The following is a description of a gene set: species: Homo sapiens Reactome Pathway: HIV Life Cycle part of: HIV Infection The life cycle of HIV-1 is divided into early and late phases, shown schematically in the figure. In the <b>early</b> phase, an HIV-1 virion binds to receptors and co-receptors on the human host cell surface (a), viral and host cell membranes fuse and the viral particle is uncoated (b), the viral genome is reverse transcribed and the viral preintegration complex (PIC) forms (c), the PIC is transported through the nuclear pore into the nucleoplasm (d), and the viral reverse transcript is integrated into a host cell chromosome (e). In the <b>late</b> phase, viral RNAs are transcribed from the integrated viral genome and processed to generate viral mRNAs and full-length viral genomic RNAs (f), the viral RNAs are exported through the nuclear pore into the cytosol (g), viral mRNAs are translated and the resulting viral proteins are post-translationally processed (h), core particles containing viral genomic RNA and proteins assemble at the host cell membrane and immature viral particles are released by budding. The released particles mature to become infectious (j), completing the cycle.<br>Most of the crucial concepts used to describe these processes were originally elucidated in studies of retroviruses associated with tumors in chickens, birds, and other animal model systems, and the rapid elucidation of the basic features of the HIV-1 life cycle was critically dependent on the intellectual framework provided by these earlier studies. This earlier work has been very well summarized (e.g., Weiss et al. 1984; Coffin et al. 1997); here for brevity and clarity we focus on experimental studies specific to the HIV-1 life cycle., and this is the list of marker genes: NUP210, XPO1, CHMP2B, VPS4A, GTF2E1, GTF2H5, RANBP2, TAF1L, AAAS, RAN, RAE1, TAF2, POLR2K, RNGTT, ELOC, PDCD6IP, TAF15, TAF9B, UBA52, GTF2B, NELFCD, SUPT16H, VPS37A, POM121C, LIG1, SSRP1, rev, RCC1, CCNH, TSG101, TAF4B, MVB12B, NUP205, NUP50, NMT2, BANF1, POLR2I, NCBP2, vpr, NUP188, VPS4B, NUP214, SUPT4H1, CXCR4, NMT1, XRCC4, UBB, CCNK, GTF2A2, CDK7, VPS37C, POLR2H, NELFB, CHMP7, GTF2A1, ERCC3, ELOA2, POLR2A, NUP43, CHMP4C, RNMT, NELFE, NUP160, NUP58, tat, GTF2H3, NDC1, POLR2E, GTF2H4, TAF6, NCBP1, POLR2J, RANBP1, VPS28, XRCC5, POLR2G, CCR5, VPS37B, ELOA, gag, NUP37, GTF2F1, SEC13 (SEC13 homolog, nuclear pore and COPII coat complex component), MNAT1, NEDD4L, CD4, TAF10, GTF2H2, KPNA1, vif, TCEA1, vpu, GTF2E2, TAF4, TAF13, LIG4, RPS27A, TPR, GTF2F2, NUP153, UBAP1, POLR2D, CCNT2, TBP, TAF7, GTF2H1, NELFA, NUP35, POLR2B, RANGAP1, PPIA, CCNT1, CHMP4B, TAF1, TAF5, ELL, FEN1, VPS37D, POLR2C, NUP85, CTDP1, CHMP3, NUP54, FURIN, VTA1, TAF7L, NUP42, ERCC2, env, TAF11, NUP155, TAF12, MVB12A, CHMP5, SEH1L, CHMP2A (charged multivesicular body protein 2A), NUP88, NUP62 (NCBI Gene Id 51551), NUP107, NUP133, SUPT5H, ELOB, CHMP6, CHMP4A, TAF9, nef, NUP98, POM121 (NCBI Gene Id 9883), NUP93, TAF3, gag-pol, PSIP1, TAF8 (TATA-box binding protein associated factor 8), XRCC6, POLR2L, UBC, HMGA1, POLR2F, CDK9